The following is a description of a gene set: Human Gene Set: ADA2_TARGET_GENES species: Homo sapiens from publication Yevshin I, Sharipov R, Kolmykov S, Kondrakhin Y, Kolpakov F (PMID 30445619) Genes containing one or more binding sites for (ADA2) in their promoter regions (TSS -1000,+100 bp) as identified by GTRD version 20.06 ChIP-seq harmonization., and this is the list of marker genes: PIGQ, SLX9, NME1, FBXL14, STX16, LOXL1-AS1 (NCBI Gene Id 100292820), FBXW8, NDUFAF1, ECE2 (NCBI Gene Id 9718), ALG10B, DPYSL2, EEFSEC, ENSG00000246465, MFSD12, LSG1 (large 60S subunit nuclear export GTPase 1), MRPS18C, GTF3C5 (NCBI Gene Id 95853), RPL27A, DDX1 (NCBI Gene Id 1653), MRPS31P5, THEM4, TSEN54, GATM, JMJD4, TMEM68, CTNNA1, FAM118A, PPP2R3C, ZNF462, PSMD11, SNRNP27, TMEM222, CUL4A, RPS10-NUDT3, WDR24, MEIS2, TEFM, APEX1, SDHAF3, DUS1L, PROX1, NOXA1, PDCD6, ZNF570, ATP6V1G2, STX6, SENP1, ZNF384, MRPL58, RRP15, TCP1, TMEM41A, PRDM6-AS1, ITGB3BP, TDP1, TAF12-DT, ZNF561-AS1, AP5Z1, LRRC58, SUPT7L, ADAP2 (NCBI Gene Id 55803), NXN, ERI1, NAT8L, LMAN2 (lectin, mannose binding 2), FAM220A, EIF3F, CSNK1D, ZNF549, CAPNS1, TMEM242-DT, UBE3B, NOP16, TMEM128, RPL13, RNPS1, GSK3A (NCBI Gene Id 2931), PPIL6, ZDHHC6, GBA1 (glucosylceramidase beta 1), GLIPR1, LDB2, PPIP5K2, LAS1L, SMPD2, ATP13A4, WDPCP, MRPL21, KMT2A, SEC11A, ENSG00000273828, WRAP53, ZNF768, TACO1 (translational activator of cytochrome c oxidase I), NR1H2, SRSF2, B4GALT7, ST6GALNAC6, ZNF646, ATL2, PSMF1, ENSG00000232995, GAP43, EEF1A1, DNAJC24, BLOC1S6, COA6, LRRC37A5P, PER1, KIAA0586, IFT56, ZNF461, ZNF276, TXN2, SPHK2, COMMD2, MINPP1, MITD1, PPID, TENM2, RPL35, WDR83OS, TUBGCP4, ZNF165, RSPH3, GTF2H2C, PSCA, ZFHX4, ZSWIM2, CSTF2T, MRPL48, METTL15, SNAP25-AS1, CPSF1, RPL38, INPP4B, CCDC57, ACOT13, DCP1A, ZNF718, LZIC, CSTPP1, INO80B-WBP1, NOL8, ZZZ3, EEF2, ZMPSTE24-DT, SLC33A1, VPS45, SREK1IP1, VWA8, RFX3-DT, C8orf33, RPL9, PSMC2, SNORD54, SLC39A13, GEMIN7, TOR1B, TRUB2, FOXI1, ZNF790 (zinc finger protein 790), NAV3, LINC00853, EIF2D, CEBPA, PLEKHG3 (pleckstrin homology and RhoGEF domain containing G3), PHF21A, C11orf68, TESC, POLR1B, ZBED9-AS1 (ZBED9 antisense RNA 1), CHAF1A, GOLGA3, CCAR2, UQCC6, UNC50, ZNF396, ZSCAN22, OGFOD2, TMEM132A, SNRPB, PDCD6-DT, DRG2, POLR3B, ALG10, YWHAE, NMNAT1, VPS36 (vacuolar protein sorting 36 homolog), AAK1, C12orf76, SNX16, MLEC, PHF20, AP3S2, ZER1, ISY1-RAB43, ANAPC7, TMEM129, E2F3, RPL36, GALK2, DMAP1, ZNF677, SOX5, MIR1302-3, MIR7-3HG, FANCM, RPL3, SAMD1, GTF2H4, PCYT1A, PPP2R2A, TATDN3, FAM228B, CUEDC2, RPS24, NUP107-DT, ADPRHL1 (ADP-ribosylhydrolase like 1), MCM7, SEMA3A, TYR, TIGD1, MRPL30, MAIP1, TGS1, UQCC1, SHOX2, MKRN2, YEATS2, STARD10, RNF220, CABLES2, ZNF581, EIF2B1, HERC3, CERNA3, GABPA, KBTBD4, ZFP62, CCDC38, WDR83, FOSL2, RUVBL1, ATG5, TRDMT1, EXD3, GLUD1P3 (NCBI Gene Id 414244), ZSCAN16-AS1, LINC02142, CWC27, RPS20, GALNT16-AS1, CFAP298-TCP10L, RESF1, CPVL, ZNF846, ZNF213-AS1, C16orf46, SCN1B, RPL7, PTPN21, SNORD46, LINC00667, ZNF391, LIAS, SLC12A5, TUFM, GET4, SELENOH, SLC39A3, MAD2L2, ZNF195, BAZ2A, EIF4G3, MKRN3, RNU7-27P, CACNA1A, SNHG6, ARPC5L, MNAT1, BASP1, PSMG3, HMGB1, GRAMD1B, SLF1, BCL9L, ADAP1, CFAP276, ELMOD1, NREP, RPL29, PGK1, FAM168A, P3H4, EIF1AD, FAM120AOS, RAP2C, HELQ, NELFA, NOSIP, ZNF302, RNF6, FBXW2, THAP10, SLC35B1, ZNF517, NELFB, FAM98B, RPL18, DPY19L3-DT, SNRPD1, NDUFC2, NFYB, CXXC4, STIM2, TRIP4, RNU6-1145P, MCM4, YIPF2, RPS2, GTF3C3, ZMYM3, CYP2A7, TNRC18, PLPP6, PUM1, ERP44, EEF1A1P23, MIR9-2HG, LSM5, ZNF710, TARS2, MKNK2, NCOA2, NUP107, CDC16, DSTYK, RFC4, C3orf38, RNU6-1, FGF7, SNHG15, CHCHD2, PRDM6, ANTKMT, RPL11, NFKBIL1, NDUFAF4P1, FAM120A, ABHD13, RPL5, ZFHX3, COA5, BORCS8-MEF2B, MDH1, DNAJC25-GNG10, VARS2, DNAJC7, SNRPD3, MRPL16, MPLKIP, PXK, ZNF564, EME2, THUMPD1, CCDC97, KCTD10, SMG8, GALNT16, ECHDC1, PTK2B, ARMC7, CELF5, KLHL20 (kelch like family member 20), INTS5, MRPL51, NFAT5, RAP2C-AS1, WDR25, COG4, ABCB9, MTHFD2L, NSUN4, ZFHX4-AS1 (ZFHX4 antisense RNA 1), LOXL1, SBDS, HOXC8, ISY1, MECOM, NUMBL, RSBN1, SMG7-AS1, ZNF410, MTCO3P12, MAP3K10, NCAPD2, RBM3, LINC01547, COA6-AS1, MRPL1, PFKM, MAP3K8, EMG1, PEX3, MRPL39, AURKAIP1, KMT2B, DBN1, MRPL44, RPS7, UBE2I (NCBI Gene Id 7329), CEACAM19, MKRN1, MNX1, SSBP1, BMS1P4-AGAP5, FAM227B, DHX33, CASKIN2 (NCBI Gene Id 57513), TAGAP-AS1, WEE2-AS1, ANXA2, AKR1B1, PLEKHA1, KCTD5, NIF3L1 (NCBI Gene Id 66010), FLI1, SNORD55, TEX38, PPIEL, SNAP47, RBBP5, DLGAP4, RPS3A, RHOXF1P1, TUT1, ZBTB20, SLC24A1, TOP3B, ELAPOR1, ACP2, PAXBP1 (NCBI Gene Id 94104), UTP3, CHD2, CDC123, STOML2, PGAM5, RAB18, HYCC2, EXOSC4, MAF1, VPS13B-DT, TGFB3, TNPO3, SEC22B, NDUFA12, HMGA2, EMC4 (NCBI Gene Id 51234), ZSCAN9, MRPL40, ARL6IP4, AGO3, ZNF827, CCNC, KLHDC9, ACAD11, EXD2, USPL1, TMEM242, TIGD5, RPS14, MAML2, IPO4, LRRC49, RPL23AP53, SLC4A1AP, VPS52, BMS1P1, ZNF579, LINC00244, NSFL1C, STMP1, YBEY, FOXN3, NFIA, NUP153, PDE6D (NCBI Gene Id 5147), RPS10, C17orf75, MRPS31, AP1G1, RPL27, NPLOC4 (NCBI Gene Id 55666), MRPL3, ATP6V1G2-DDX39B, TSSC4, PYURF, ADGRA2, ATPAF1, MTG1, RTEL1, DNAJC25 (DnaJ heat shock protein family (Hsp40) member C25), HSP90AA1, ZNF623, MTERF4, ENSG00000263011, CLOCK, CELF4, MRPS34, NXT2, COPS7B, SNORD84, BMS1P4, PIGC, KIF22, VPS16, FAM241A, PPP1R11, INVS, ZNF770 (zinc finger protein 770), HUS1, CPLX2, SF3B6, WDR31, DNAJC2, WSCD1, ZNF582, SPAG8, CYREN, ALKBH3, TRIM35, PIH1D2, BBS1, TACC3, CGGBP1 (NCBI Gene Id 8545), BRWD3, PEX13, MCM3AP, ARMH3 (armadillo like helical domain containing 3), EEF1D, SMIM20, DCDC1, TRABD, KIAA0825, ZNF850, NDOR1, FBXO22, EVX2, NRN1, MED18, VPS9D1, OSGEP, HASPIN (histone H3 associated protein kinase), SAR1B, EXOSC3, ALG3, SNORA9, GPBP1L1 (NCBI Gene Id 60313), COMMD1, BRF2, NOL12, RNFT2, TESC-AS1, ZNF580, ZBTB11-AS1, EIF5B, HDAC8, NR1H3, MED23, LIG4, NOP2, ABRAXAS1, INTS14, DPP9, IPPK, RPL37, FKBP3, TRMU, ERCC6L2, ZNF791, GIN1, TSPAN10, INTS12 (integrator complex subunit 12), APBA3, TUBGCP3, TYW5, TPI1P2, PIGL (phosphatidylinositol glycan anchor biosynthesis class L), CACNG8, TXNDC9, GTPBP3, C16orf46-DT, RNA5SP283, ENPP3, NICOL1, PUS10, NKAPD1, SLC20A2, SLC35C2, TMEM69, MTRF1, PPP1R9B, TIGD6, GATA3, PHKA2, SPRING1, AP4M1, VWA8-AS1, PCID2, MRPL54, DDX39B, SMG7, FGFBP3, SPRED3, IFTAP, RTTN (NCBI Gene Id 284278), TBC1D19, MIR3677HG, MIR3928, TMA16, FZD1, ELOA, EIF4A2, BRD2, TMEM203, SPDL1, STX16-NPEPL1, EIF4E2, RFX3, POC1B, DNAJB12, ZNF582-DT, MDGA1, MIR7-3, ZBTB46-AS1, ARHGAP1, BANP, CACNG2, TBC1D13, EDC4, CCT4, TOR1AIP1, RPS8, GUCD1, MNX1-AS1, BCAT2, ENSG00000267260, SCRT1, PRPF18, MAGI1, MAN1A2, REXO4, ZBTB20-AS4, KRR1, ANXA4, SUGT1, HIRA, DDX39B-AS1, ANAPC5, WDR11, HAR1A, EIF4G1, MRPL13, YJU2, USP30, COPS2, ATR, COQ3, RPL32, ZNF596, NIPBL, TIMM9, ERCC6L2-AS1, RPS3, PDGFB, PROX1-AS1, G0S2, RFXANK, WDR11-DT, EIF2B5 (NCBI Gene Id 8893), CCDC159, MTR, RBBP9, B3GALT9, JPX, RBM28, AMDHD2 (NCBI Gene Id 51005), ADAT2, H2BC4, PRSS27, FOXS1, SNHG9, SNORA78, BBS10, TDP2, ACBD6, SLC4A11 (solute carrier family 4 member 11), OTUD7B, EIF3D, ZNF561, SH2B1, GFM1, ZNF205, MTIF2, MAN2C1, UBE3C, BCL11A (BCL11 transcription factor A), RPL7A, MARK4, PDCD6IP, CTDSP2, CEBPA-DT, LINC01410, RPS29P16 (ribosomal protein S29 pseudogene 16), FZD2, TIMM29, BMS1, TMX4-AS1, RNU6ATAC, BTNL12P, ZBTB11, CLK3, TSC22D4, SLC44A1 (NCBI Gene Id 63942), SH2D2A, DDX21, MCOLN1, LINC01132, MRPL18, C21orf91, C2CD2L, TAF12, KLK10, PRORP, PSMG3-AS1, TMEM101, DPY19L4, NR2F1-AS1, NPAS3, EFCAB7, TTC4, ZBTB45 (NCBI Gene Id 84878), SNORD15A, NKAPP1, FRA10AC1, RPS18, UBIAD1, CACNG2-DT, SNORD24, NDUFB3, YY1, DTD1, VPS25, NME1-NME2, EPCIP-AS1, LTN1, ZSCAN20, NDUFA11, DDIT4, ZNF408, GSTCD, VPS51, IGHMBP2, SBK1, WARS1, PEMT, MPHOSPH10, TTC23L-AS1, MRPS22, HEMK1, RPL8, METTL9 (methyltransferase 9, His-X-His N1(pi)-histidine), RPS4X, CNBD2, UBA5, C18orf21, SNORD43, SUGT1-DT, PHB2, SUGCT, GRB2, YEATS2-AS1, NEU3, MRPS31P4, COQ4, NKAP, MED22, OPA1 (NCBI Gene Id 4976), MYBL1, TUT7, MCEE, SLCO4A1, MBTPS2, LMOD1, AFG2B, HNRNPF, DPY19L3, SLC12A5-AS1, CYSRT1, VTI1A, KCNJ5, MST1, KAT2A, HMGXB3, TECPR1, ZNF569, PATJ, AIFM2, GGN, FANCC, NAA20, NDUFS7, TNPO1, NR2F2, NUP54, ZCCHC2, ZNF490, PCED1A, ACSF3, FKBP10, DPAGT1, SLC27A5, STK3, SYNPO, STX18, COPS4, GFM2, KNSTRN, CDK5RAP1, MAMDC2-AS1, STARD3, WNT2B, STX18-AS1, TEDC1, PSTK, YIPF3, POLR1C, MCAT, RPL31, TES, VCPIP1, ZNF682, SHARPIN, INO80B, PPIL3, LAMP1, AMDHD1, PDXK, AMOTL1, GTF2H3 (NCBI Gene Id 2967), SSBP2, BCL9, NDUFS3, PDCD2, BORCS8, NSL1, AQR, CTNNA1-AS1, NUDCD3, ZC3HC1, KMT5B, BCL6, DDX55, AAR2 (AAR2 splicing factor), MTMR9, SLC35A3, WDR36, VPS13B, ZSCAN29, SBDSP1, DCTN1, RNF123, C10orf88, COX16, SNORD68, FEM1B, ZMPSTE24, RSPO2, MTBP, BRI3, GRPEL2, AGK, SEC13, MIR1538, SCAND3, NDUFC2-KCTD14 (NCBI Gene Id 100532726), ISM1, BASP1-AS1, NUDT5, NORAD, TTC23L, SF3B3, DPH7, ANKRD40, DHX33-DT, TSEN15, PRRG2, STMN3, JRK, CENPP, H2AZP3, MTMR4, NUF2, ITGAE, SCRIB, MTOR, RGS5, MSL1, TVP23B, CDK5RAP3, GOLM2, DTWD1, H2AZ1-DT, LRRC32, CSNK1E, RNF185, SNORA7A, NSA2, LETM1, CCDC106, SMIM19, LINC03065 (NCBI Gene Id 105370833), RHOXF1P2, ZNF668, SF3A3, LINC03057, MFAP2, BANF1, CFAP298, PCLAF, MFSD11, PLEKHM3, GLUD1P2, ATP5PF, AGK-DT, PMS2P4, CCKBR, NR2F1, HSPB9, DRAP1 (DR1 associated protein 1)